Given this list of marker genes SLC13A5, SLC13A2, SLC25A21, SLC25A11, SLC22A6, SLC22A7, SLC13A3, here is a description of the gene set: The directed movement of alpha-ketoglutarate into, out of or within a cell, or between cells, by means of some agent such as a transporter or pore. Human Gene Set: GOBP_ALPHA_KETOGLUTARATE_TRANSPORT studied in species Homo sapiens